The following is a description of a gene set: The process, occurring in the embryo, by which the anatomical structures of the digit are generated and organized. A digit is one of the terminal divisions of an appendage, such as a finger or toe. species: Mus musculus Mouse Gene Set: GOBP_EMBRYONIC_DIGIT_MORPHOGENESIS, and this is the list of marker genes: Zbtb16, Ihh, Hoxd13, Msx2, Tbx3 (NCBI Gene Id 52240), Tbx2, Wdpcp, Wnt5a, Lrp5, Hoxd11, Chst11, Ror2, Bcl2l11, Mycn, Hoxa11, Bmp4, Megf8, Osr1, C2cd3, Flvcr1, Gli3, Gja1, Shh, Cplane1, Osr2, Sall1, Notch1, Tmem107, Fuz, Ttbk2, Hdac1, Hdac2, Intu (inturned planar cell polarity protein), Tbc1d32, Gna12, Ctnnb1, B9d1, Alx4, Prickle1, Twist1, Frem2, Lrp4, Tmem231, Ift140, Sfrp2, Hand2 (NCBI Gene Id 15111), Hoxc11, Wnt7a, Grhl2, Bpnt2, Mks1, Traf3ip1, Lnpk, Map3k20, Fzd6, Ift122, Gnaq, Hoxd12, Rab23, Tulp3, Bax, Msx1, Ift52, Lrp6, Gli2, Fbxw4, Gas1, Ift88, Ece1, Lmbr1, Smad4, Bmpr1a, Nog